The following is a description of a gene set: species: Homo sapiens part of: RHO GTPase cycle This pathway catalogues RHOD GTPase activator proteins (GAPs) and RHOD effectors. RHOD possesses GTPase activity and is therefore grouped with classical RHO GTPases but it is atypical in the sense that no known guanine nucleotide exchange factors (GEFs) and no GDP dissociation inhibitors (GDIs) are involved in the regulation of RHOD activity. RHOD possesses an elevated intrinsic guanine nucleotide exchange activity and auto-activates (Jaiswal, Fansa et al. 2013). RHOD regulates cytoskeletal dynamics and intracellular transport of vesicles, especially actin-dependent movement of endosomes. Reactome Pathway: RHOD GTPase cycle, and this is the list of marker genes: WHAMM (NCBI Gene Id 123720), ESYT1, PGRMC2, VAPB, FILIP1 (NCBI Gene Id 27145), EMD, ARHGAP35, RHOD, AKAP12, ARHGAP39, PIK3R2, ARHGAP21, STEAP3, SLC4A7, VANGL1, MOSPD2, ACTN1, LMAN1, TOR1AIP1, CPNE8, PLXNB1, VAMP3, DEPDC1B, DBN1, HINT2, ARHGAP1, CAV1, PAK5, CAPZB, DIAPH2, ANKFY1, MCAM (melanoma cell adhesion molecule), ARHGAP32, PIK3R1, ARHGAP5, EFHD2, ARHGAP17, LEMD3, DIAPH3, STBD1, PAK6, LBR, RACGAP1, ADD3, GOLGA8R, ARHGAP12, DIAPH1, LMNB1, VRK2, ARHGAP26, TMPO, RAB7A, PLXNA1